The following is a description of a gene set: species: Mus musculus Genes predicted to be targets of miRBase v22 microRNA mmu_miR_297c_5p in miRDB v6.0 with MirTarget v4 prediction scores > 80 (high confidence targets). from publication Chen Y, Wang X (PMID 31504780) Mouse Gene Set: MIR_297C_5P, and this is the list of marker genes: Manea, Samt4, Gm12253, Pstpip2, Nsd2, Pfkfb2, Ro60, Zfp970, Fancd2os, Or51ab3, Arhgap25, Prokr2, Smoc2 (SPARC related modular calcium binding 2), Zfp966, Clec5a, Arpp21, Col4a5, Cimip2b, Xrcc3, Plaat3 (phospholipase A and acyltransferase 3), Papss2, Ifi202b (NCBI Gene Id 26388), Car5b, Pramel27, Acot8, F830016B08Rik, Gpatch8, Ice1, Cdc73, Camta1, Olfm3, Slc12a1, Sim1, Gbp4, Cdc23, Wdr82, Slco3a1, Bltp3b, Htr3b, Ptprk, Zfp729a, Lamp2, Epyc, Tnfsf15, Ppp1r1c, Csf2rb2, Crebrf, Mrgpre, Lcorl, Brinp1, Rfx3, Slc5a8, Clrn1, Insm1, Zfp1009, Glcci1, Foxc1, 4930444P10Rik, Fgf7 (fibroblast growth factor 7), Usp25, Il18r1, Ypel5, Cacna1g, Epc1, Evi2b, Prr11, Eif4enif1, Heyl (NCBI Gene Id 56198), Zfp729b, Trub2, Il21, Cplx2, 6030458C11Rik, Rock2, Myo9a, Azin1, Casp8, Zfx, Lrch1, Ptbp3, Cdk8, Homer1, Spef2, Gnaq, Zfp831, Arhgef33, Ids, Ell2 (NCBI Gene Id 192657), Slc35d2, Zfp967, Kcnj3, Serpinb1a, Cyria, Riox2, Kras, Gm94, Naa11, Nrxn1, Ano4, Extl3, Wdr33, Zfp26, Stum (NCBI Gene Id 96945), Amotl1, Aldh1l2, Nxpe3, Ldb3, Ppp6r2, Gabrb3, Fam169b, Tbc1d24, Pank1 (pantothenate kinase 1), Oxgr1, Tasor2, Tomt, Cpsf2, Dclre1c, Dpp4, Gadl1, Abraxas1, Fmn2, Snurf, Jhy, Sarnp, Mindy2, Acer3, Hivep1 (NCBI Gene Id 15271), Or12j5, Serp1, Crppa, Steap2, Vwc2, Pramel22, Rnf220 (NCBI Gene Id 70613), Cdh11, Oprd1, Tfap2b, D630023F18Rik, Sorcs3, Spryd7, Ago3, Dusp16, Pcdh10, Snrpn, Sfi1, Cemip (NCBI Gene Id 83495), Pank3, Spn, Atrn, Cops2, Tcf7l2, Csnk2a2, Galnt12, Cep295, Rab7, Ccpg1, Itgb1bp1, Elapor2, Bcl2, Zbtb43, Zfp945, Kcnab2, Gria4, Wsb1, Csf2rb, Dusp7, Lrrn4cl, Brwd3, Ntrk3, Dnm3, Heph, Fech